The following is a description of a gene set: studied in species Homo sapiens Human Gene Set: MCM2_TARGET_GENES from publication Yevshin I, Sharipov R, Kolmykov S, Kondrakhin Y, Kolpakov F (PMID 30445619) Genes containing one or more binding sites for (MCM2) in their promoter regions (TSS -1000,+100 bp) as identified by GTRD version 20.06 ChIP-seq harmonization., and this is the list of marker genes: TRAPPC9, SLC16A3, VPS51, NDC1, CHD9NB, ARHGEF5 (Rho guanine nucleotide exchange factor 5), DNHD1, TMEM91, TMEM11-DT, UCKL1, THA1P, PANK4, APOBEC3G, AAMP, GSK3A, NPRL2 (NPR2 like, GATOR1 complex subunit), TSSC4, BANP, ST3GAL2, TCEA2, CHMP4B, CALCOCO1, FAM222A, MADCAM1-AS1, TMEM115, PIPOX, ACVR1, CDCA3, PSMD11, NCLN, GTF2H4, TUBA1C, AHDC1, RAB43, SAXO5, BRD7, DDX23, RNA5S12, CIAO1, BOD1, LRRC37B, RN7SL371P, TRIM41, TMEM164, DESI2, BRD3OS, FAM13A, PHF23, PNKD, FBXL19, VARS2, PEMT, CYB561D2, TMEM11 (NCBI Gene Id 8834), UNK, TSC22D4, GSPT1, ORMDL3, HDGF, DSTYK, PPP1R18, TCEANC2, FBXL19-AS1, DBP, C1orf159, TMEM127, CRTC2, H3-3B, TMEM59, PPP1R12B, USP30, ZNF341-AS1, PRCC (proline rich mitotic checkpoint control factor), KLHL22, DFFA, CLPB, IFRD2, ZFYVE1, FEM1A, ABCF2, STAU1, RALA, UPP2, AP2S1, PHF12, CALR3, C19orf44, PHB1